Given this list of marker genes Rnf213, Tlr2, Atg16l1 (autophagy related 16 like 1), Calcoco2 (NCBI Gene Id 97692), Nod1, Nod2, Lgals8, Irgm1, Tbk1, Lrsam1, Wipi2, Rnf31, Irgm2, Mapk3, Ripk2, Optn, Igtp, here is a description of the gene set: Mouse Gene Set: GOBP_XENOPHAGY species: Mus musculus The selective degradation of intracellular pathogen or some part of an intracellular pathogen (e.g. viral capsid) by macroautophagy.